The following is a description of a gene set: Cdc6 is a regulator of DNA replication initiation in both yeasts and human cells, but its mechanism of action differs between the two systems. Genetic studies in budding yeast (S. cerevisiae) and fission yeast (S. pombe) indicate that the normal function of Cdc6 protein is required to restrict DNA replication to once per cell cycle. Specifically, Cdc6 may function as an ATPase switch linked to Mcm2-7:Cdt1 association with the Cdc6:ORC:origin complex. In S. cerevisiae, Cdc6 protein is expressed late in the M phase of the cell cycle and, in cells with a prolonged G1 phase, late in G1. This protein has a short half-life, and is destroyed by ubiquitin-mediated proteolysis, mediated by the SCF complex. Human Cdc6 protein levels are reduced early in G1 but otherwise are constant throughout the cell cycle. Some reports have suggested that after cells enter S phase, Cdc6 is phosphorylated, excluded from the nucleus and subject to ubiquitination and degradation. Replenishing Cdc6 protein levels during G1 appears to be regulated by E2F transcription factors. part of: Assembly of the pre-replicative complex studied in species Homo sapiens Reactome Pathway: CDC6 association with the ORC:origin complex, and this is the list of marker genes: ORC2, ORC6, ORC4, ORC5, ORC3, CDC6 (NCBI Gene Id 990), MCM8, ORC1 (NCBI Gene Id 4998)